Given this list of marker genes MYOCD, GLYR1, KMT2A, ARID1B, ALKBH1, PRMT3, KDM1A, EP300, KAT7, APOBEC3C, SPI1, L3MBTL3, PHF2, ATF2, TET1, EGR1, RBM14, APOBEC3F, ASH2L, ZMPSTE24, SMARCB1, VPS72, WDR5, TET3, USP21, CTCFL, ATAD2B, ATAD2 (ATPase family AAA domain containing 2), MEN1, ZNHIT1, APOBEC2, SMARCD1, AICDA, BRD7, SPHK2, TDG, APEX1, KDM1B, MACROH2A1, PADI2, SIRT7, ALKBH4 (NCBI Gene Id 54784), SAMD1, ARID1A, SGF29, KAT2B, FAM47E, KAT8, TRMT112, N6AMT1, APOBEC3A, TP53, DPY30, WBP2, OGG1, APOBEC1, NOC2L, TET2, APP, RBBP5, SMARCA4, here is a description of the gene set: An epigenetic process that increases gene expression at specific genomic regions through chromatin remodeling either by modifying higher order chromatin fiber structure, nucleosomal histones, or the cytosine DNA demethylation. Human Gene Set: GOBP_POSITIVE_REGULATION_OF_GENE_EXPRESSION_EPIGENETIC studied in species Homo sapiens